Given this list of marker genes NDUFAF1, ITFG2-AS1 (NCBI Gene Id 647957), INTS14, CLPB, STOML2, LIFR, SLC10A7 (solute carrier family 10 member 7), PSMF1, VPS52, LAS1L, PAXBP1, VARS2, PRRG2, BCKDHA, PUS10, UAP1, POLR3E, WDR83OS, ARPC5L, MUS81, ZEB2-AS1, PEX13, RPS15A, IFTAP, MIX23, PDE6D, C12orf43, RBFOX2, ZNF282, VTRNA1-3, NCAM1, ZNF689, ENSG00000246308, CCDC107, SLMAP, BANF1, CWC27 (CWC27 spliceosome associated cyclophilin), HDAC2-AS2, DIAPH1, TULP3, NOC4L, WTAP, IL15, SMG7-AS1, NKAPP1, DALRD3, ZBTB37, MMADHC-DT, FAM227B, ABRAXAS2, NKAP, POLDIP3, BIRC2, BMS1P4-AGAP5, PCID2, PARP6, RPSAP31, PROSER1, TMEM79, EPCIP-AS1, MITD1, SBDSP1, DTWD1, TRUB1, AGAP2, TMEM213, MTERF4, GALK2, VPS13B-DT, RNF10, FNBP1, MRPS2, RNU5A-1, RAB18, ENSG00000247416, FERRY3, SNHG29, PEX5, TAF15, NSL1, RPL6, YARS1, ELF1, DHX33-DT, RNU7-27P, DGAT2, MED18, YAP1, KCTD10, RERE, CEPT1, CDC16, ARF5, MIR6068, B3GALNT2, PICART1, EIF1AD, ADPGK-AS1, OTUD7B, RASGEF1B, RPL22L1, GLI1, CPSF1, ATP13A4, MT-TS2, FAAH, SLC24A1, NOXA1, POLG-DT, SAMD4B, GIN1, JOSD1, CASP7, ATXN2L, DDX51, TRIM2, EPOR, STEAP2-AS1, SNHG12 (small nucleolar RNA host gene 12), BAZ2A, CFAP298, OSBPL7, HACD3, FAHD1, DNAJC24, TRIM23, CFAP298-TCP10L, ZNF609, KDM3B, TRIP4, ZNF775, COQ8A, KRBA1, DNM1, EIF4G2, TIPIN, EXOSC8, GGPS1, TAF12, ARPC3, TLE2, FLNB, CACNA1A, LINC01775, DDX59, NKX2-1, ADGRV1, CDC73, PDCD6P1, IPO4, SSBP2, NVL, ILF2, CCDC59, NEK8, NDUFAF4P1, NOL12 (nucleolar protein 12), NKAPD1, DDX55, ZSCAN16-AS1, HNRNPH3, MCF2L, HSP90AB1, MROH2A, ZNF770, B4GALT7, UTP3, ZMYND12, TMEM30A, WDR47, MISFA, NME1-NME2, SNHG5, GTF2H4, RCOR3, C17orf75, SNORD46, RNF103, AGBL5-AS1, NIF3L1, NUF2, TIMM9, EXD2, ZNF433-AS1 (ZNF433 and ZNF878 antisense RNA 1), HEXIM1, ENSG00000263011, GPBP1L1, ZNF302, SNORD49A, FRA10AC1, PSME3IP1, ICE2, CACNG8, ATP5MF-PTCD1, NKIRAS1 (NFKB inhibitor interacting Ras like 1), RNA5SP212, TF, AIFM1, MTOR, TMEM41A (transmembrane protein 41A), ZNF616, P2RX6, MRPL21, NDUFC2, PPP6R1, MBTPS2, NDUFS3, ATP2B4, TPTEP2, PPIL3, CCAR2, SNORA16A, GTPBP3, ZFYVE9, DHX30, ZKSCAN2, NHLRC3, KCTD2, DHX16, C1GALT1C1, EME2, ADPGK, ZC3HC1, CNIH3, EFCAB7, NSA2, OPA1, NDUFC2-KCTD14 (NCBI Gene Id 100532726), RPS7, PIERCE1, PLEKHG5, DPY19L4, TBL1X, PITHD1, CDK12, IMP3, OGT, TM9SF2 (transmembrane 9 superfamily member 2), TACO1, OTUB2, ARHGEF12, ZNF579, IRX6, INTS2, ITSN1, DRAM2, DDX1, SNORD3A, SNHG7, MOCS2-DT, DOC2A, DHPS, MRPS31P5, UEVLD, HIVEP1, SUGCT, DNAJC25, IFT74, STAT3, AP4M1, KDELR1, MRPL16, MFAP3L, ZNF221, MAN2C1, ANKS3, SLC33A1 (NCBI Gene Id 9197), TUT1, LZIC (leucine zipper and CTNNBIP1 domain containing), DSTYK, MTF2, TPI1P2, TNNC1, TMEM30A-DT, TCTN3, MT-CYB, NR2F1-AS1, ZNF827, LZTS3, ENSG00000228496, ZNF131, JRK, JPX, SUPT3H, PRKAB2, MPHOSPH10, MED22, PRPSAP1, TSPAN31, ZNF205, MRPL48, FASTKD5, ING1, NUP107-DT, HMGXB3, LINC01359, HOMER1, VPS13B (vacuolar protein sorting 13 homolog B), HMGXB4, GTF3C3, MRPL30, WDR11, TMEM101, ACBD6, RHNO1, DGAT1, EML2, FBXW8, SFT2D2, ELOVL2-AS1, SLC25A23, SETD1A, ZNF570, ID2, SERP1, HDAC2, SMO, E2F6, GEMIN7, RAB11FIP2, HELQ, ALG10, MTMR9, RASD2, MRPS18C, ISY1-RAB43, ZNF3, RPL7A (NCBI Gene Id 6130), ZEB2, NOL8, NUP107, BCAR3, MRPL40, APOM, TSC1, RNVU1-14, TIAL1, PCYT1A, MRPL39, ADGRE2 (adhesion G protein-coupled receptor E2), CDK1, LINC00431, HTR3A, KIAA0408 (KIAA0408), RBSN, MESD, CFAP20, BRWD1, TRBV13 (NCBI Gene Id 28574), GOLGA3, AP4E1, H4C2, DTX3, NRSN2-AS1, TMEM11, KANSL1, EXOSC3, VPS51, KANSL3, PAFAH2, RGS5, NALT1, RPS8, LINC01168, METTL25, JMJD4, ZSCAN25, UBE3B, ZNF569, ACOT7, TRAPPC13, ARID4B, GTF3C5, MVK, RHOT2, RPL29, VPS45, TMEM248, ARID5B, ZMPSTE24, ARHGEF16, PRPF31, MRPL3, MOK, MIR4521, PPIP5K2, DNAJC25-GNG10, CRHR1, NCEH1, SELENOH, ZSCAN9, ABHD4, WNT5A, DDX19A-DT, DMAP1, SRP72P2, NAGA, NAGLU, KCTD5, TAF12-DT, ITGB3BP, DDX19A, LINC00240, KDM3A, TMEM242-DT, MCM7, ATP6V0E2, R3HDM2, KDM5C, CCDC167, AJUBA, ZNF821, TMED1, AGK, NME1, METTL15, ZNF771, AAR2, GTF2IP20, MPP2, NPLOC4, FGF9, STX18, C19orf12, UBOX5, PCLAF, TMEM68, CCT6A, SLCO5A1, FOXM1, STMP1, TBC1D19, DPP9, RPL15, HECTD1 (HECT domain E3 ubiquitin protein ligase 1), EPB41L4A-AS1, ZNF213-AS1, VPS25, CASC3, DLEU1, GFM2, MKRN2, KLHL20, ANKRD13D, WDR70, DMAC2L (distal membrane arm assembly component 2 like), RAB13, RTTN, DHX33, WEE2-AS1 (NCBI Gene Id 285962), NR5A1, KBTBD4, CIZ1, PSMD3, CDC42SE1, BMS1P4, SSBP1, CROCCP2, MT-TH, PIGL, IER5, SNORD118, FAM230G, S100PBP, ATP5MF (NCBI Gene Id 9551), SLC39A11, GABPB2, CUL4A, TATDN3, OAZ3, ITGA3, TICRR, PIH1D2, NUCB1, WDR83, CASC2, TFPT, GSTO1, POLR3B, ADAP2, EIF3E, TMEM69, CASTOR3P, ADAT2, MIR4674, TAFAZZIN, MAPT-AS1, MARK4, CCNI (cyclin I), GRHL3, MDFIC, NUDT19, ANO8, ALDOA, MCF2L2, RFC3, PPCS, MED4, AGBL5, GALNT16-AS1, TTC4, SPEF2, TGS1, SLFN11, RPL41, SLC25A21, MIR4519, CCDC88A, RAB11A, SLFN5, GSTCD, PPP1R35-AS1, RNVU1-27, TRMT61B, PHACTR4, VWA8-AS1 (VWA8 antisense RNA 1 (head to head)), ABHD13, ZNF165, ZBTB45, AHCYL1, COX16 (cytochrome c oxidase assembly factor COX16), TARS2, AP3S2, TLCD1, MED23, H4C8, IGDCC4, ARK2N, MTND5P11, GPR89B, ENPP3, ZER1, NOSIP, GAS5, TLCD3B, SNRPB, MAPT-IT1, SF3A3, NUDT5 (NCBI Gene Id 11164), MAPK3, LIG4, ARID1A, CENPP, DISC1, TRAM1, LINC01569, SNORA13, KIAA0586, CYB5RL, GRHL3-AS1, BANP, DNAJB12, ZC3H6, C1orf50, ALKBH3 (alkB homolog 3, alpha-ketoglutarate dependent dioxygenase), COMMD4, TOB2, NOP16, NEK9, MTR, SEPTIN7P13, RNU5B-1, SRRM3, SRP9, ISY1, FUS, PRPF18, HDGF, ZNF433, LINC01166, TSFM, USP30 (NCBI Gene Id 84749), ECHS1, HCG14, EIF2B3, RUNDC3B, EXD3, PSMB3, VWA8, CDK5RAP1, DNAJC2, THAP10, ZMPSTE24-DT, SHLD3, SUPT7L, RNU6-573P, STT3B, MRPS34, RCAN1, INTS6, SEC13, UBB, KANSL1-AS1, CCDC77, SEC22B, LSG1, UQCC6 (ubiquinol-cytochrome c reductase complex assembly factor 6), HMGB1, HIPK4, MBD6, SNORD55, MOCS2, ZNF580, MTCO3P12, KMT2A, MTIF2, RMRP, ZNF233 (zinc finger protein 233), MALAT1, TSPAN10, SMG8, PSCA, DNAH2, HAGH, NUDT15 (nudix hydrolase 15), PEMT, DDIT3, GTF2B, RNVU1-34, NMNAT1, EDC4, CCNG2, LRP5L, MIR548AW, FGFBP3, SREK1IP1, HNRNPA1, ST7, CALM1, DCDC1, MLEC, MRPL9, LINC02593, CDC123, SMG7, ANXA2R, STX16-NPEPL1, CCNL1, PARL, GUCD1, SSR4, TCF3, ZBTB4, CAPS2 (calcyphosine 2), SNRNP35, ARHGAP1, EYA1, RORA-AS1, FANCM, VPS50, GRPEL2, AJUBA-DT (NCBI Gene Id 107984660), CWF19L1, PHIP, REEP5, GFI1B, FAM200A, COPS7B, PLXDC1, STEAP2, GLUD1P3, CCNC, TRDMT1, RDH14, VPS72, FCHSD2, CUEDC2, KCTD3, PLAA, DRG2, IST1, AURKAIP1, RNU12, TKT, ZNF704, KDM5A, RBL1, INTS6-AS1, RAD52, RUVBL1, LIFR-AS1, PEX3, POLG, ZNF581, ZNF331, CENPU, TVP23B, MIR6731, MBL1P, FUT10, LACTB2-AS1, MPP7-DT, FAM98B, PSTK, NAPEPLD, TSEN15, CLTC, IFT56, RPL5, INO80C, FAM162A, MPLKIP, KLHDC9 (NCBI Gene Id 126823), GPR101, UBE2B, AFG1L, ATXN7L3, TOP3B, MIR1302-3, SNUPN, MST1P2, STX16, NOTCH1, INTS5, COMMD2, RPL36, SLC4A1AP, RBBP5, METAP2, LRRC37A5P, NUDT19-DT, DNAJC28, CTNNB1, ARHGEF1, NDUFS7, SAR1B, ARHGAP45, BAG6, IDH3G, IGHMBP2 (immunoglobulin mu DNA binding protein 2), ARL6IP1, EIF3F, SLC44A1, PTPN11, INKA2, MYOF, HIRA, DDX49, RPS18, TEFM (NCBI Gene Id 79736), ANAPC5, USPL1, STX6, BRF2, MIR762HG, SNORD49B, C19orf53, BCAN-AS2, ANKRD13B, BMS1, CDKL3, TGIF1 (NCBI Gene Id 91941), NEAT1, METTL9, TADA1, MRPL44, PTGES3, DHX9, COQ5, NFE2L2, RPS4X, COPS2, PSPH, H2BC26, SPRED1, NDUFAF3, STX18-AS1, PKNOX1, WDR24, NSFL1C, FAM133B, ID2-AS1, RAD51AP1, KMT5B, TMEM242 (NCBI Gene Id 729515), EEF1A1P23, ZBTB40, ZNF461, PTCD1, C12orf76, RPL37, ADORA2A, DCP1A, RBM28, PTMA, STAT6, ADRA1A, PDE4A, GBA1, MT-TL2, AGK-DT, WDR36, TMEM63A (transmembrane protein 63A), LINC01547, TSC22D4, MCEE, LRRC49, SLCO5A1-AS1, ATXN7L3-AS1, MAP3K3, SLX9, WDR62, PMF1, SLC39A3, MRPS31, NR0B2, ALG5, REXO4, C18orf21P1, PIAS3, PLEKHM3, CD8A, RRP15, SMG5, FBXO4, WDR11-DT (WDR11 divergent transcript), SMARCD2, SNRPD3, PMF1-BGLAP, CCDC137, ST7-OT4, RPL38, NR1H2, C10orf88, SNAP47, WDR26, ZNF408, TNPO3, ZNF391, BNIP1, NDUFA12, POLR2A, PFN2, NISCH, TAB3, CCDC97, ENSG00000232995, CAMKK1, NRSN2, MRPS31P4, PSMC2, KRR1, ERBIN-DT, MRPL58, PPARD, DPP8, DUS1L, FOXJ3, ENSG00000260136, LANCL2, EIF2D, PTCH1, INTS12, ANKRD40, ATF1 (activating transcription factor 1, NCBI Gene Id 466), UNC5B, here is a description of the gene set: Human Gene Set: GLI4_TARGET_GENES from publication Yevshin I, Sharipov R, Kolmykov S, Kondrakhin Y, Kolpakov F (PMID 30445619) Genes containing one or more binding sites for (GLI4) in their promoter regions (TSS -1000,+100 bp) as identified by GTRD version 20.06 ChIP-seq harmonization. studied in species Homo sapiens